The following is a description of a gene set: studied in species Homo sapiens Pyroptosis is a form of lytic inflammatory programmed cell death that is triggered by microbial infection or pathological stimuli, such as stroke or cancer. The process of pyroptosis protects the host from microbial infection but can also lead to pathological inflammation if overactivated. The morphologic characteristics of pyroptosis include cell swelling, rupture of the cell membrane and release of intracellular contents into the extracellular environment. Pyroptosis is also characterized by chromatin condensation, however this is not the key or universal feature of pyroptosis. Pyroptosis is executed by proteins of the gasdermin family, which mediate formation of membrane pores (Liu X et al. 2016; Ding J et al. 2016; Mulvihill E et al. 2018; Broz P et al. 2020). Pyroptosis can be defined as gasdermin-mediated programmed necrotic cell death (Shi J et al. 2017; Galluzzi L et al. 2018). The gasdermin (GSDM) superfamily includes GSDMA, GSDMB, GSDMC, GSDMD, GSDME (or DFNA5) and PJVK (DFNB59) (Kovacs SB & Miao EA 2018). Each protein contains an N-terminal domain with intrinsic necrotic pore-forming activity and a C‑terminal domain reported to inhibit cell death through intramolecular domain association (Liu X et al. 2016; Ding J et al. 2016; Liu Z et al. 2018, 2019; Kuang S et al. 2017). Proteolytic cleavage in the linker connecting the N‑ and C‑terminal domains of gasdermins releases the C‑terminus, allowing the gasdermin N‑terminus to translocate to the cell membrane and oligomerize to form pores (Shi J et al. 2015; Ding J et al. 2016; Sborgi L et al. 2016; Feng S et al. 2018; Yang J et al. 2018; Mulvihill E et al. 2018). Although PJVK (DFNB59) is included to the gasdermin family, it is not known whether PJVK is cleaved and whether the full length or the N-terminal portion of PJVK is responsible for forming membrane pores. The N‑terminal fragments of GSDMs strongly bind to phosphatidylinositol phosphates and weakly to phosphatidylserine, found on the inner leaflet of the plasma membrane (Liu X et al. 2016; Ding J et al. 2016; Mulvihill E et al. 2018). Gasdermins are also able to target cardiolipin, which is often found in mitochondrial membranes and membranes of bacteria (Liu X et al. 2016; Rogers C et al. 2019). The size of the GSDMD pore is estimated to be 10–20 nm (Ding J et al. 2016; Sborgi L et al. 2016). The pore‑forming activity of GSDMs in the cell membrane facilitates the release of inflammatory molecules such as interleukin (IL)‑1β and IL‑18 (mainly in GSDMD-mediated pyroptosis), and eventually leads to cytolysis in mammalian cells, releasing additional proinflammatory cellular contents including danger signals such as high mobility group box‑1 (HMGB1) (Shi J et al. 2015; He W et al. 2015; Evavold CL et al. 2017; Semino C et al. 2018; Volchuk A et al. 2020). Pyroptosis can occur in immune cells such as macrophages, monocytes and dendritic cells and non‑immune cell types such as intestinal epithelial cells, trophoblasts and hepatocytes (Taabazuing CY et al. 2017; Li H et al. 2019; Jia C et al. 2019). GSDME can be cleaved by caspase‑3 (CASP3) to induce pyroptosis downstream of the “apoptotic” machinery (Wang Y et al. 2017; Rogers C et al. 2017), whereas GSDMD is cleaved by inflammatory CASP1, CASP4 and CASP5 in humans, and CASP1, CASP11 in mice to induce pyroptosis associated with inflammasome activation (Shi J et al. 2015; Kayagaki N et al. 2015). CASP3 cleavage of GSDMD results in its inactivation. In mouse macrophages, CASP8 can also cleave GSDMD and cause pyroptosis when TAK1 is inhibited (Malireddi R et al. 2018; Orning P et al. 2018; Sarhan J et al. 2018), and TAK1 inhibition also leads to GSDME cleavage (Sarhan J et al. 2018). Furthermore, activated CASP8 can drive inflammasome-independent cleavage of both pro-IL-1β and GSDMD downstream of the extrinsic cell death receptor signaling pathway switching apoptotic signaling to GSDMD-dependent pyroptotic-like cell death (Donado CA et al. 2020). The cleavage and activation of GSDMD in neutrophils is mediated by neutrophil elastase (NE or ELANE), which is released from azurophil granules into the cytosol during neutrophil extracellular trap (NET) formation (Kambara H et al. 2018). Further, granzyme A (GZMA) released from cytotoxic T lymphocytes and natural killer (NK) cells specifically target GSDMB for interdomain cleavage to activate GSDMB-dependent pyroptosis in target tumor cells (Zhou Z et al. 2020). Similarly, granzyme B (GZMB) released from cytotoxic T lymphocytes and natural killer (NK) cells, can induce GSDME‑dependent lytic cell death in tumor targets via the CASP3‑mediated cleavage of GSDME (Zhang Z et al. While the N‑terminal domains of mammalian GSDMA, GSDMB, and GSDMC also have the ability to form pores (Feng S et al. 2018; Ruan J et al. part of: Regulated Necrosis Reactome Pathway: Pyroptosis, and this is the list of marker genes: GSDME, TP53, CHMP2A, CHMP2B, CASP1, IRF2, CHMP3, ELANE (NCBI Gene Id 6417), CHMP4C, GZMB, IRF1, CHMP4B, TP63, CHMP4A, CASP5, IL18, GSDMD, CHMP7, BAX, IL1B, BAK1, CHMP6, CASP4, HMGB1 (NCBI Gene Id 3146), CASP3, IL1A, CYCS